The following is a description of a gene set: c-myc is a well-known proto-oncogene encoding for a transcription factor that needs to be tightly regulated in order to preserve cell homeostasis. The Promyelocytic Leukaemia gene product PML plays an important role in cell growth and survival, and resides in discrete subnuclear structures called Nuclear Bodies (NB). We performed comparative analysis of the expression of 40 Myc target genes and of Myc binding to their regulatory regions both in wild-type and PML knockout cells. We demonstrate that if PML is absent, despite Myc binding to the DNA regulatory sequences is unchanged, the expression profile of several Myc target genes is altered. PML is largely involved in gene regulation, via recruitment of several transcription factors and cofactors to the NB. Consistently, we show that Myc partially localizes to the NB and physically interacts with PML, and that this localization depends on Myc expression levels. As deregulation occurs to both activated and repressed Myc target genes, we propose that PML influences Myc transcriptional activity through a mechanism that involves the control of Myc post-translational modifications. from publication Cairo S, De Falco F, Pizzo M, Salomoni P, Pandolfi PP, Meroni G (PMID 15735755) Mouse Gene Set: CAIRO_PML_TARGETS_BOUND_BY_MYC_DN studied in species Mus musculus Genes down-regulated in MEF cells (embryonic fibroblasts) after knockout of PML and whose promoters were bound by MYC., and this is the list of marker genes: Cdkn2b, Cdkn2a, Ccnd1, Cdkn1a, Pdgfrb, Erbb2, Cav1, Irf9, Bcat2, Hspa1b, Cdkn1b, Adm, Tert